The following is a description of a gene set: Human Gene Set: GOBP_POSITIVE_REGULATION_OF_VASCULOGENESIS Any process that activates or increases the frequency, rate or extent of vasculogenesis. species: Homo sapiens, and this is the list of marker genes: CD34, RIN2, ADM, RAPGEF2, KDR, HIF1AN, CEACAM1, RAMP2, RAP1A, RRAS, ASB4, TMEM100